The following is a description of a gene set: Human Gene Set: GOBP_RESPONSE_TO_COCAINE species: Homo sapiens Any process that results in a change in state or activity of a cell or an organism (in terms of movement, secretion, enzyme production, gene expression, etc.) as a result of a cocaine stimulus. Cocaine is a crystalline alkaloid obtained from the leaves of the coca plant., and this is the list of marker genes: SNCA, CHRNB2, SLC1A1, MDM2, DNMT3A, DRD5, CRH, DRD3, DRD4, HOMER1, FKBP5, PPP1R1B, SDK1, CRHBP, SLC1A3, EN1 (NCBI Gene Id 2019), OXT (oxytocin/neurophysin I prepropeptide), CDK5, HTR2A, TACR3, CCNA2, FOSB, PITX3, CREB1, ST8SIA2, HDAC2, HDAC5, HSP90AA1, OPRK1, DRD1, MYRF, FADD, GRM2, SLC1A2, CACNG4, EHMT2, RGS4, GPRIN3, ABAT, GRIA1, SLC6A4, COMT, TGM2, EFTUD2, SMPD1, SLC6A3, HOMER2, DRD2